The following is a description of a gene set: Human Gene Set: MIR761 species: Homo sapiens Genes predicted to be targets of miRBase v22 microRNA hsa-miR-761 in miRDB v6.0 with MirTarget v4 prediction scores > 80 (high confidence targets). from publication Chen Y, Wang X (PMID 31504780), and this is the list of marker genes: FBLN5, TBL1XR1 (TBL1X/Y related 1), ZNF609, ZNF214, CCDC103, CPEB1, OXR1, BRPF3, PRR23B, PPM1L, CXXC5, CLASP1 (NCBI Gene Id 23332), SLC8A1, QKI, RAB4B, PPP6C (protein phosphatase 6 catalytic subunit), GATD3, MMS19, TMEM33, PHACTR3, ACSL1, HPSE2, KIF13A, CTSS, IKBKB, PHF20L1, NEURL1B, NSD1, MAPK8, DLL1, TAFA4, ZFHX3, GPN1, YWHAZ, RIMS3, PTER, FGF14, PPP2CB, KPNA1, VSTM4, KBTBD2, HR, GARRE1, JPH1, RAPGEFL1, PROX1, RAP1GAP2, CREBL2, SLC36A1, GFRA1, CERT1, NAA50, CMTM4, TGOLN2, PRR14L, CSF1, ZBTB20, TMEM86A, HMG20A, IPO7, KIF21B (kinesin family member 21B), MECOM, C1orf226, RGS22, TSPAN11, LUZP1, FGFR1, FBXO32, UBE2R2, DUSP15, GALNT7, PHF6, GPR6, C17orf49, PCMT1, PIK3CB, IRS1, LHX6, PCDH20, KCNC4, KIF7, STK32B, CTNNB1, PIM1, RALGAPB, MTCL2, BAX, ALPK2, USP24, ADSS2, CBR4, MED19, EXOC3L2, PAN2 (NCBI Gene Id 9924), TAOK1 (TAO kinase 1), PARP16, AMMECR1L, PGF, IGSF3, NUFIP2, BCL2L11, LRP2, CHD2, ZBTB39, KCNC2, ATP2A3, MEAF6 (NCBI Gene Id 64769), COG5, NMB, KSR1, MAP3K4, FNDC5 (NCBI Gene Id 252995), COP1 (COP1 E3 ubiquitin ligase), GLOD5, NAA15, MPI, SIGMAR1, LARP1, ZNF710, MLLT10, PURB, RNF169, NEO1, PCLO, GDNF, ERFE, PLAGL2 (NCBI Gene Id 5326), PDLIM5, NFIA, DOLPP1 (dolichyldiphosphatase 1, NCBI Gene Id 89888), GCC2, PGGT1B, KRTAP4-4, TNPO1, PLA2G3, USP20, TMEM248, CPSF4, PDE11A, EXOC2 (NCBI Gene Id 55770), SARM1, PLXDC1, USP46, TRAF1, LSM12, ZNFX1, CAPN11, TANC2, TRA2B, TMEM43, GNAL, ATP8B2, PHF21A, JAKMIP2, ERRFI1, ZBTB10, CBL, SNX12, PDE5A, SLC25A39, ST6GALNAC1, RUBCN, USP3, SMYD5, ATG16L1, SEC24C, NFATC2, TRAF3, KMT5A, BTAF1, CNIH1, DMXL2, SLC25A25, ATP8A1, RPUSD1, MBLAC2, IPO11, ZFAND3, GPR85, RAB14, HMGN3, INO80C, CEP44, MYO1D (myosin ID), AKAP13, RBM34, BTBD1, RCSD1, ACVRL1, MLXIP, UBE4A, CBX2, IL17RD, FAM110D, ARID3B, EDF1, OPRK1 (NCBI Gene Id 4986), NOMO3, MTMR3, ITGB8, RPIA, DHRS12, HMGN4 (NCBI Gene Id 10473), CLSTN1, DBNDD1, TMEM161B, MTA3, PYM1, GSK3B, MAPK1, VPS53 (NCBI Gene Id 55275), CPEB4, FAM20B, DAGLA, MAK16, SEC31A, MFN2, BCL11A, RC3H1, GALNT18, BAZ2A, SOX8, UBL4B, F8, SLC23A2